The following is a description of a gene set: Human Gene Set: GOBP_4_HYDROXYPROLINE_METABOLIC_PROCESS The chemical reactions and pathways involving 4-hydroxyproline, C5H9NO3, a derivative of the amino acid proline. The presence of hydroxyproline is essential to produce stable triple helical tropocollagen, hence the problems caused by ascorbate deficiency in scurvy. This unusual amino acid is also present in considerable amounts in the major glycoprotein of primary plant cell walls. studied in species Homo sapiens, and this is the list of marker genes: EGLN2, HOGA1, ALDH4A1, P4HB, PRODH, GOT2